Given this list of marker genes CYP1A1, HPGDS, HPGD, CYP4B1, CYP1A2, CBR1, AWAT1, ALOX15, ALOX12, CYP2C9, CYP4A22, PTGDS, EPHX2, GGT1, CYP4F3, CYP1B1, MAPKAPK2, CYP2U1, CYP8B1, PTGES3, DPEP1, DPEP2, FAAH, PTGES2, CYP2C8, PON2, PTGS1, PON3, PRXL2B, ALOX12B, PTGIS, CYP4F11, CYP4F22, PLA2G4A, GPX2, LTA4H, CYP4F8, CYP4A11, ALOXE3 (arachidonate epidermal lipoxygenase 3), ALOX15B, SLC27A1, CYP2J2, AKR1C3, GGT5, ALOX5, PTGS2, CYP4F2, PON1, ABCC1, TBXAS1, LTC4S, PTGR2 (NCBI Gene Id 145482), CYP2C19, GPX4, PTGES, GPX1, ALOX5AP, FAAH2, PTGR1, here is a description of the gene set: Arachidonate metabolism species: Homo sapiens Human Gene Set: REACTOME_ARACHIDONATE_METABOLISM